Given this list of marker genes CHPF2, ARF6, TNPO3, XAB2, CLDN8, NAT9, RFX2, DSP, AQR, STUB1, ENSG00000286190, GRIN2C, ADAM19, CARD19, INTS5, SEC24C, NUDC, CEP41, HS3ST1, LAS1L, CAPN15, UBE3A, SLC25A36 (NCBI Gene Id 55186), TBCEL, FOS, LENG8, SFMBT2, TEKT2 (NCBI Gene Id 27285), IGFBP5 (insulin like growth factor binding protein 5), PKDCC, DNAAF4, CBFA2T2, JTB (NCBI Gene Id 23561), ADSS1, HEPACAM2, ACAA1, LRRC49, OXSR1, ARPC1B, MTDH, SRRM1, DCTN1, TMEM268, KMT5C, ACAA2, TBX1, PON1, SPA17, ANXA8 (NCBI Gene Id 653145), IGFBP6, DEXI, UCHL5, EGR1, RP9, BCL9, LYPLAL1, IGHM, BCL9L, DMKN, SOX18, AEBP1, LIMD1, HERC2, MROH1, EMC6, PBRM1, SIN3B, CFAP141, CEP70, TM9SF1, PIM2, MARCO, IST1, ESRP1, CYSTM1, BPHL, ACSS1, SOS2, TNFAIP6 (TNF alpha induced protein 6), ALOX12, ABCB6 (ATP binding cassette subfamily B member 6 (LAN blood group)), KPLCE, CCN1, SNHG8 (NCBI Gene Id 100093630), OS9, RAP2C, LRPPRC, DHX36, SF3A2, SLC11A2, SIN3A, ZNF322, SCGB3A2, CAMTA2, WNT11, ATF1, LDHB, CDPF1, ANP32A, CBX4, SLC16A11, RXRA, HES1, WDR90, CSNK1D, AAMP, XPR1, PIGR, APPL2 (adaptor protein, phosphotyrosine interacting with PH domain and leucine zipper 2), CDH23, TRIM23, KLC3, EXOSC7, HEXIM1, DAPP1, CP, FAM216A, HACD3, CDIP1, SNX11, KEL, ELOA, GMNN, ZDHHC6, AP2A2, SREBF1, USP36, CLUAP1 (clusterin associated protein 1), CYP27B1, WDTC1, SSBP3, RECQL4, CYP4V2, OXT (oxytocin/neurophysin I prepropeptide), PPIG, ADPRM, RPS27, JUND, GAS1, MSL1, RBX1, CNTLN (NCBI Gene Id 54875), SDHAF1, NFKBIZ, HAGH, HIBADH, PPP1R21, RUNX1T1, TMPRSS2, ARID4B, MED16, FLCN, EFNA1, ZIK1, MAP3K3, UTP20, AP1M2, POLR2A, HTRA2, RAB34, MYB, NFYC, CDC42EP3, HGH1, THNSL1, SPATA13, CNOT4 (NCBI Gene Id 4850), FXYD6, SUMO3, DDX3Y, SMCO4, ATP6AP2, NME7, MTARC2, SOX2, LMNA, DHRS11, AFTPH, TCP11, EIF3G, OSER1, WDR33, RDH13, IRF4, DLG3, MRPL47, SCRIB, ELOF1, ATN1, CYP2F1, TNK2, DYNLT1, NRDE2, NOSIP, IFT46, FASTKD1, GID4, CCKAR, RSPH9, FAM43A, here is a description of the gene set: We previously identified toll-like receptor 4 (Tlr4) as a candidate gene responsible for ozone (O3)-induced pulmonary hyperpermeability and inflammation. The objective of this study was to determine the mechanism through which TLR4 modulates O3-induced pulmonary responses and to utilize transcriptomics to determine TLR4 effector molecules. C3H/HeJ (HeJ; Tlr4 mutant) and C3H/HeOuJ (OuJ; Tlr4 normal), mice were exposed continuously to 0.3 ppm O3 or filtered air for 6, 24, 48 or 72 hr. Affymetrix Mouse430A_MOE gene arrays were used to analyze lung homogenates from HeJ and OuJ mice followed using a bioinformatic analysis. Inflammation was assessed by bronchoalveolar lavage and molecular analysis by ELISA, immunoblotting, and transcription factor activity. TLR4 signals through both the MYD88-dependent and independent pathways in OuJ mice, which involves MAP kinase activation, NF-kappaB, AP-1, and KC. Microarray analyses identifiedTLR4 responsive genes for strain and time in OuJ versus HeJ mice (p<0.05). One significantly upregulated cluster of genes in OuJ were the heat shock proteins (Hspa1b; Hsp70), Hsp90ab1). Furthermore, O3-induced expression of HSP70 protein was increased in OuJ compared to HeJ mice following 24-48 h O3. Moreover, BAL polymorphonuclear leukocytes (PMN) and total protein were significantly reduced in response to O3 in Hspa1a/Hspa1btm1Dix (Hsp70-/-) compared to Hsp70+/+ mice (p<0.05). TLR4 signaling (MYD88-dependent), ERK1/2, AP-1 activity, and KC protein content were also significantly reduced after O3 exposure in Hsp70-/- compared to Hsp70+/+ mice (p<0.05). These studies suggest that HSP70 is involved in the regulation of O3-induced lung inflammation through the TLR4 pathway and provide evidence that HSP70 is an endogenous in vivo TLR4 ligand. Genes down-regulated in comparson of lung tissue from wild type mice subjected to ozone for 6 h vs that from TLR4 deficient animal subjected to ozone for 6 h. from publication Bauer AK, Rondini EA, Hummel KA, Degraff LM, Walker C, Jedlicka AE, Kleeberger SR (PMID 21543283) Human Gene Set: GSE20715_WT_VS_TLR4_KO_6H_OZONE_LUNG_DN studied in species Homo sapiens